Given this list of marker genes Atrx, Lbr, Chaf1a, Trim28, Sp100, Nipbl, here is a description of the gene set: Mouse Gene Set: GOMF_CHROMO_SHADOW_DOMAIN_BINDING Binding to a chromo shadow domain, a protein domain that is distantly related, and found in association with, the chromo domain. species: Mus musculus